Given this list of marker genes DEF6, NFKB1 (NCBI Gene Id 4790), IFIH1, AIRE, IGKC, CTLA4, IPO8, FASLG, CDH1, ELF4, CASP10, SYK, SKIC2, SKIC3, LRBA, FOXP3, IGHG2, FAS, STAT3, FOCAD, CARD8 (caspase recruitment domain family member 8), RIPK1, here is a description of the gene set: Gastritis The presence of inflammation of the gastric mucous membrane. species: Homo sapiens Human Gene Set: HP_GASTRITIS